Given this list of marker genes TMEM100, BTG2, SEC24A (SEC24 homolog A, COPII coat complex component), OOEP, BTAF1, SIK1, KIF23, ARHGAP20, PAFAH1B2, KLHL2, HMBOX1, DESI1, ZBTB44, RFX3, RAB9A, MKNK1, ETNK1, PLAG1, DDX3X, SGK1, PLPP1, MEX3C, AMMECR1, USP42, TBP, HECTD1, P3H2, CCND2, PIK3R1, JARID2, DENND2C, ABCF3, RET, GALNT7, HIPK2, RNF217, DPY19L4, C1QL3 (complement C1q like 3), PISD, RBBP6, ELL, MAP3K9, MYO5A, YWHAH, GAREM1, ZC3H13, PDZD8, OMG, SUCO, GATAD2A, ADGRL1, RAD50, JPH3, TAB3, SLC36A1, UNC13A, SOX6, RPS6KA6, SCN8A, FAM135A, SEMA3A, CD80, MYLK, PRRC2C, BZW1, ARMCX2, NAPG, ELMOD1, MTMR3, NRP2, CLCN4, AGO4, PDK4, ATXN7L3B, MYO5B, PAG1, OTX1, PTPN4, UNC5D, WIPI2, ABHD2, TMEM154, AMOTL1, IFT74, RAB30, NOS1, PLXNA4, TMC7, ZNF691, EGLN1, NSMF, SIPA1L2, SLC9A6, FBXO21, NAV1, HIGD1A, COP1, ANO3, TMEM135, CDC25A, VEGFA, LSM11, MOB3B (MOB kinase activator 3B), TRAM1, KDSR, MYEF2, PHF19, WWC1, MTFR1L, EXOC3L2, KCNK10, HELZ (NCBI Gene Id 9931), BAG4, GRM7, MIDEAS, QKI, EZH1, SSR1, PCDH17, SRPRA, ARHGDIA, RUNX1T1, NHLRC2, IGF2R, MEOX2, PAFAH1B1, SLC6A11, PEDS1-UBE2V1, UNC80, HTR4, ATF6, CD3E, GSTCD, ZNF449, PEX13, UBE2V1, HSPG2, TCAIM, LUZP1, CDK17, ZBTB20, SLIT2, ANKS1A, ZCCHC3 (zinc finger CCHC-type containing 3), PPP1R11, UBE4B, KCTD8, KRTAP11-1, RETREG2, BCL2L2, KCNJ2, KIF3B (kinesin family member 3B), MOB4 (NCBI Gene Id 96815), UBR3, CYP2S1, MED26, PDIA6, DYNC1LI2, LAMP3, LRP2, TMEM199, RPS6KA3, GNAT1, STXBP5, RASSF8, DCP1A, KRTAP4-6, FAM133B, PELI2, PLXNC1, CDK8, TRABD2B, ZSCAN31, DMPK (NCBI Gene Id 60405), SOBP, ST7L, HTR2A, SLC20A2, YTHDC1, DDX3Y, PAPPA, ATXN7L2, LRP6, SNRPB2, TMEM245, UBE4A, CC2D1B, LRRN3, ARMH4, PIP4P2, RELN, ZNF367, RBPJ, SALL1, ATXN7L3, TSC22D2, DENND1B, SLC35G1, RBM24, STXBP3, PTPRR, CMPK1, NR2C2, GABARAPL1, MAP2K1, ZNF622, ILDR2, CASR, NF1 (NCBI Gene Id 646021), LURAP1L, VPS33B, ISLR, DCLK1, TMCC1, SPTBN2, DEPDC4 (NCBI Gene Id 120863), N4BP1, SH3GL2 (SH3 domain containing GRB2 like 2, endophilin A1), LDLRAD2, CBX2, SMIM13, KIF21A, SYT4, TRANK1 (tetratricopeptide repeat and ankyrin repeat containing 1), WBP11, WDTC1, PCMT1, ACTR2, ATG14, MNT, EPC1, SHOC2, RNF10, ARFGAP2, ATXN1L, SCOC, LRRK1, CDC42SE2, USP44, AGO1, EYA1, ENSG00000275993, APLN, USP31, CD47, RICTOR, PPT2, MCU, RAB11FIP2, STOX2, TMEM183A, NUP50, SPRED1, NFATC3, PPM1E, ACOX1, FGF7, DENND4A, CREBRF, PLRG1, GALNT13, CACNA2D1 (calcium voltage-gated channel auxiliary subunit alpha2delta 1), STRADB, ARIH1, SON, CCNE1, G2E3, VPS4A, EPHB2, DLL1, EPHA7, GPATCH8, IPPK, ZFHX3, ACVR2B, TGFBR3, CPSF7, NUFIP2, AHCYL2, FGFR1, CLOCK, SAMD10, HERC6, COBLL1, SERBP1, ZCCHC2, MYB, CARM1, ATXN2, UBE2Q1, SKI, SALL4, BTRC, TBL1XR1, C1orf21, SESN1, CACNA1E, COL12A1, ZNHIT6, AXIN2, KCNG4, NRN1, ARHGAP12, CAPZA2, ZFHX4, MASP1, OGT, DNAJB4, CASK (NCBI Gene Id 8573), KCNN4, RARB, SIRT4, SYNRG, SLC4A4, FBXW7, RSPO3, TNFSF13B, RASGEF1B, TRIM66, STK33, SETD3, GFAP, INSR, IVNS1ABP, CYP26B1, LATS1, CPD, SLC25A37, PNPLA6, PABIR2, PPM1A, CHD2, ADAMTS3, WNK3, RBM12, KANK1, PTPRD, AVL9, MGAT4A, SEL1L3, CSRNP1, SEH1L, DYRK1B, SAV1, ATG9A, CFAP45, ZDHHC15, TNRC6B, TLK1, GLS2, ELAC1, MKX, CEP85L, GCC2, POU2F1, GHR, FAM110C (family with sequence similarity 110 member C), FASN, CHEK1, ZBTB39, ARHGAP32, UROS, USP25, KIF5C, CDC37L1, KIF1B, PTH, TFCP2L1, NOB1, FAM81A, TMEM268, UBN2, FAM89A, CCDC6, ZNRF3, PDE3B, PRDM4, CBX4, CXCR5, WNT3A, PPP2R1B, ZNRF2, TFAP2A, NECTIN1, ABL2, DMTF1, ZMAT3, RAB9B, UBFD1, USP3, LRIG1, ATXN7L1, AMER1, MFN2, CAPRIN1, SYNJ1 (synaptojanin 1), UBQLNL, FBXL20, LGR5, CPEB3 (cytoplasmic polyadenylation element binding protein 3), RECK, ADRB2, SOCS6, AKT3, CCND1, ARL2, SYPL1, RNF144B, SLC13A3, SMURF1, SYT3, SYDE2, TENM2, FGF2, PCDH9, UTP25, EDA, CBX6, NCS1, PIP4P1 (NCBI Gene Id 90809), CACUL1, CCDC88C, CD2AP, FOXK1, ANKRD46, DIXDC1, TUBA4A, MAMSTR, PTPN3, CDK5R1, MAP3K13, IKBKB, IPO7, FAM91A1, ROCK2, LRIG2, SEPTIN2, HEPHL1, FLT3, SEMA6D, HMGA1, CHPT1, HSPA4L, SLC12A2, SSTR3, SUMO3, CNOT6L, CSDE1, CYB561A3, SMAD7, CPEB2, TMEM178B, KIF5B, CMC4, TLL1, BCL11B (NCBI Gene Id 64919), CCNT1, SPTLC1, RFK, ASH1L, PPP6R3, SREK1, SNTB2, ARL3, AK4, NAA25, FERMT2, DRD1, CHAC1, SLC39A10, GPR63, ACVR2A, C12orf76, E2F3 (NCBI Gene Id 1871), COPS7B, C2orf42, RASEF, RS1, SLC11A2, MAN2A2, SPRYD3, AMOT, CUX1, ZBTB46, RBM6 (NCBI Gene Id 646559), ANKUB1, SNX16 (NCBI Gene Id 64089), PARVA, RAD23B, RUNDC3B, PIAS2, CHUK, RREB1, ATG13, MYBL1, TBPL1, CDCA4, IARS1, TARBP2, TGIF2 (TGFB induced factor homeobox 2), USP15, ZBTB34, LITAF, NSG1, ZC2HC1A, ZMYM2, LAMC1, WNT7A, ST8SIA3, CHIC1, SEMA5B, CEP55, ENAH, WEE1, LARGE2, GGA3, XPO7 (NCBI Gene Id 23039), CLUH, SLC2A14, here is a description of the gene set: Human Gene Set: MIR424_5P studied in species Homo sapiens Genes predicted to be targets of miRBase v22 microRNA hsa-miR-424-5p in miRDB v6.0 with MirTarget v4 prediction scores > 80 (high confidence targets). from publication Chen Y, Wang X (PMID 31504780)